Given this list of marker genes NOD2, NFKB1, MIRLET7B, TFEB, UMOD, RASGRP4, IL33 (NCBI Gene Id 90865), DEFB136, MARCHF2, MPEG1, CXCL6, SLC15A2, here is a description of the gene set: studied in species Homo sapiens An defense response against a bacteria mediated through an innate immune response. An innate immune response is mediated by germline encoded components that directly recognize components of potential pathogens. Human Gene Set: GOBP_ANTIBACTERIAL_INNATE_IMMUNE_RESPONSE